Given this list of marker genes PALMD, APIP, FST, MMUT, EN2, SPIN1, RALGAPB, ANTXR1, FAM227B, HACD1, HDAC9, SRR, CLIP4, PRKAA2, RNF114, ATP2B4, MTHFD2L, STXBP5, KCNJ3, ENPEP, DCAF4L2, TREM1, SNAI2, RNF150, MYT1, C3orf38, GABRG2, ZNF292, FGF12, ZFAND1, LRRC2, HRH4, PIK3CG, BHLHE41, LHX1, BLTP3B, CSRNP2, HACD4, RAP1B, STIM1, PLB1, SLC15A2, BZW1, here is a description of the gene set: Genes predicted to be targets of miRBase v22 microRNA hsa-miR-8058 in miRDB v6.0 with MirTarget v4 prediction scores > 80 (high confidence targets). from publication Chen Y, Wang X (PMID 31504780) studied in species Homo sapiens Human Gene Set: MIR8058